Given this list of marker genes SRRM4, ZFR2, CHD5, EPC2, PPP1R10, BTBD7, PARP11, ARL11, FAM168B, DEDD2, ST8SIA4, YWHAH-AS1, SVOP, PAFAH1B1, PDE6D, ST18, CLIC5, FBXO33, FOXP1, ENDOV, TMEM18, ZNF333, UTP18, ORAI2, IRF2BP2, PDP2, DEPDC5, FAM78A, TNIP1 (TNFAIP3 interacting protein 1), TTC7B, PGAP6, NPPC, C14orf119, PHF21A, POLR3A, SCN1A (NCBI Gene Id 6323), RBL2, TEAD3 (NCBI Gene Id 7005), GLCCI1, CCDC25, MAOB, TMEM39A, CBX2 (chromobox 2), CNN1, ACTR1A, SCLT1, PAFAH1B2, PAIP2, SCN3A (NCBI Gene Id 6328), SYT11 (NCBI Gene Id 92303), NFIC, CELF5, MYCL, WASL, MBTD1, SLC29A3, ZNF641 (zinc finger protein 641), SCN2A, PTGER4, CEP350, FBN2, CLHC1, GAS7, RAB23 (NCBI Gene Id 64438), STX1A, MTF2, ISY1-RAB43, TPM1, PLA2G2C, IL6R, COPS7A, TTC4, TP53BP2, IMPG2 (NCBI Gene Id 51443), RAD51D, RHOA, CUL4A, CREB5, COP1, RAPGEF2, ALDH1A2, APOBEC3G, CYB561D1, GRIA4, SRF, FAIM2, ZNF821, PTBP1, RORA, PER1, RAB43, TENT5A, BTN2A2, SHC1 (SHC adaptor protein 1), PDE8B, BAIAP2, AGO1, ARL3, SEC13, GALNTL6, PAN3, TMEM178B, MMP24, IGF2BP1, ANKRD28 (NCBI Gene Id 23243), SOX12, XBP1, PIK3R1, ENC1, PATL1, EXT2 (NCBI Gene Id 2132), NBEA, SLC5A7, RIMKLA, IQSEC1, LYRM1, ADPRS, OGFOD2, LHX6, TAOK1, KATNIP, SPATA13, CSNK1A1, MEOX1, LSM11 (LSM11, U7 small nuclear RNA associated), PTPRE (NCBI Gene Id 5791), FMNL3, ZNF706, MAPKBP1, RAB7A, PID1, here is a description of the gene set: from publication Chen Y, Wang X (PMID 31504780) Human Gene Set: MIR1207_3P Genes predicted to be targets of miRBase v22 microRNA hsa-miR-1207-3p in miRDB v6.0 with MirTarget v4 prediction scores > 80 (high confidence targets). studied in species Homo sapiens